The following is a description of a gene set: Genes negatively differentially expressed in cell type: γδ T cell upon treatment with cytokine: IL-3 in mouse lymph nodes in vivo. Mouse Gene Set: CUI_T_CELL_GD_IL3_RESPONSE_DN species: Mus musculus from publication Cui A, Huang T, Li S, Ma A, Pérez JL, Sander C, Keskin DB, Wu CJ, Fraenkel E, Hacohen N (PMID 38057668) Cytokines mediate cell-cell communication in the immune system and represent important therapeutic targets. A myriad of studies have highlighted their central role in immune function, yet we lack a global view of the cellular responses of each immune cell type to each cytokine. To address this gap, the authors created the Immune Dictionary, a compendium of single-cell transcriptomic profiles of more than 17 immune cell types in response to each of 86 cytokines (>1,400 cytokine-cell type combinations) in mouse lymph nodes in vivo. A cytokine-centric view of the dictionary revealed that most cytokines induce highly cell-type-specific responses. For example, the inflammatory cytokine interleukin-1β induces distinct gene programmes in almost every cell type. A cell-type-centric view of the dictionary identified more than 66 cytokine-driven cellular polarization states across immune cell types, including previously uncharacterized states such as an interleukin-18-induced polyfunctional natural killer cell state., and this is the list of marker genes: Fos, Klf6, Jun, Junb, Dusp1, Ppp1r15a, Nr4a1